The following is a description of a gene set: species: Homo sapiens Genes regulated in MCF7 cells (breast cancer) by expression of the full-length form of ERBB2 at 60 h time point. from publication Pedersen K, Angelini PD, Laos S, Bach-Faig A, Cunningham MP, Ferrer-Ramón C, Luque-García A, García-Castillo J, Parra-Palau JL, Scaltriti M, Ramón y Cajal S, Baselga J, Arribas J (PMID 19364815) HER2 is a tyrosine kinase receptor causally involved in cancer. A subgroup of breast cancer patients with particularly poor clinical outcomes expresses a heterogeneous collection of HER2 carboxy-terminal fragments (CTFs). However, since the CTFs lack the extracellular domain that drives dimerization and subsequent activation of full-length HER2, they are in principle expected to be inactive. Here we show that at low expression levels one of these fragments, 611-CTF, activated multiple signaling pathways because of its unanticipated ability to constitutively homodimerize. A transcriptomic analysis revealed that 611-CTF specifically controlled the expression of genes that we found to be correlated with poor prognosis in breast cancer. Among the 611-CTF-regulated genes were several that have previously been linked to metastasis, including those for MET, EPHA2, matrix metalloproteinase 1, interleukin 11, angiopoietin-like 4, and different integrins. It is thought that transgenic mice overexpressing HER2 in the mammary glands develop tumors only after acquisition of activating mutations in the transgene. In contrast, we show that expression of 611-CTF led to development of aggressive and invasive mammary tumors without the need for mutations. These results demonstrate that 611-CTF is a potent oncogene capable of promoting mammary tumor progression and metastasis. Human Gene Set: PEDERSEN_METASTASIS_BY_ERBB2_ISOFORM_6, and this is the list of marker genes: SYTL4, MCTP1, PRAG1 (NCBI Gene Id 157285), IL2RB, GDPD1, GSTM3, AMIGO2, CCDC68, SACS, MGP, CAMK2N1, TAF1A, ITGB2, SOCS2, BRINP2, UGT2B28, GUCY1B1, SLITRK6, RNF32, RBM24, AOX1, LOXL1, KMO, PDK4, PROM2, SDR16C5 (NCBI Gene Id 195814), SERPINA3, FAM83B, RAB27B